Given this list of marker genes PABPC5, LHFPL4, PEPD, REXO5, LTC4S, CYB561A3, PLEKHH3, NT5C2, HOXD9, HSCB, WDR90, SLC29A3, TRMU, RASGRF2, BMP4, LGI4, C17orf75, FGFR2, CENPH, POLI, NPR2, FCSK, OPHN1, LENG8, LTO1, CUBN, EMCN, ABL1, COMMD9, CYP2E1, DLG2, PLEKHA7 (NCBI Gene Id 651754, pleckstrin homology domain containing A7), LYPLAL1, BTBD2, OSR2, CAMKK1, ECHDC3, ZHX3, TTC38, IL20RB, DYNC2LI1, HCAR1, CHST12, OLFML1, PHAF1, MERTK, FAM83D, RANBP6, AGTR1, SPICE1, ACBD4, HOXB3, SPOCK2, TYK2, ADAM33, CLDN22, GSTT1, ACAT2, PAQR4, NDE1, BTNL9, VHL (von Hippel-Lindau tumor suppressor), CHDH, GRK4, PRR12, LOXL3, ZBTB8A, TRPC3, SKI, SRPX2, MMS19, SLC45A3, CENPP, MYO7A, GREB1L, MFSD11, ZFYVE19, UCN2 (NCBI Gene Id 90226), MRGPRF, PROCA1, PBLD, NICN1, CBX2, DZIP1L, DDAH2, FMO5, SFXN3, CYP2F1, LAMA1, SPRING1, SPMIP3, MMP11, YPEL4, INTS9, POU4F1, TTC21B, SLC25A23, CPT1C, GNPDA1, PRRG3, GANC, PCSK7, LRRC17, PLEKHG5, MAVS, GLIS2, SNN (NCBI Gene Id 8303), SLC27A1, TCF19, APCDD1, LASP1, NPEPL1, SNX33, ACAA1, CD248, PYGB, VSIG4, TCAF1, STC2, BMF, APH1B, MESP2, CFAP96, FKBP1B, IFT46 (intraflagellar transport 46), AR, CHIC1, TRIM37, ZFP30, ADAMTS6, SIRT2, CD300LG, MFSD12, RUNX1T1, PXMP4, SRGAP3, NOVA1, DLK2, SNX21, VPS33B, MAP6, ATP8B2, TP73, HS1BP3, MITF, MARVELD1, SLC46A3, RHEBL1, ISLR2, GRIK5, GTF3C1, TTC12, SESN1, MRNIP, TNRC6C, FGD5, ABCA4, INHA, COX6B2, GUCY1B1, CHRDL2, AHSP, PABPC4L, DHODH, SNCAIP, TNFRSF25, TUSC2 (NCBI Gene Id 11334), CD5L, TBL2, SKA2, OXTR, TNS2, GJA4, FABP4, CANT1, RDM1, CNTLN, ZNF862 (zinc finger protein 862), KLF15, WDR13, USP54, SYT17, EDEM2, AGFG2, EGLN2, CCDC61, TM7SF2, TFAP2E, ANGPTL2, KCNC1, CYP27A1, FZD2, CTIF, ZFTA, IFT140, ARVCF (ARVCF delta catenin family member), CNIH2 (cornichon family AMPA receptor auxiliary protein 2), SLC38A9, FNDC10, BANK1, here is a description of the gene set: Murine Cytomegalovirus (MCMV) infection leads to early activation of various immune cells, including B and T lymphocytes, before the actual initiation of antigen-specific adaptive immunity. This activation is partly driven by innate cytokines, including type I interferon (IFN), which are induced early after infection. The objective of this study was to address the role of type I IFN in shaping early/innate B and T cell responses to a primary acute viral infection. In order to decipher the specific impact of IFN-I on cell subsets, we performed a genome-wide expression analysis on WT splenic B and CD8 T lymphocytes isolated from C57BL/6 mixed bone marrow chimera mice. This study complements series GSE39555, which focused on early responses of NK cells and of the two subsets of conventional dendritic cells. Human Gene Set: GSE45365_CTRL_VS_MCMV_INFECTION_NK_CELL_UP Genes up-regulated in NK cells: control versus acute primary viral infection. species: Homo sapiens